Given this list of marker genes DNAJC3, SMN2, GJB1, SCN9A, BIN1 (bridging integrator 1), HARS1 (NCBI Gene Id 3035), POLG, FXN, PGM3, TYMP, FBLN5 (NCBI Gene Id 11268), MYF6, MYH14, MTMR14, OPA1, NEFL, OPA3, SLC5A6, VCP, HSPB3, COASY, ALDH18A1, SLC9A1 (NCBI Gene Id 6548), POLG2, LIFR, PNPT1, ACOX1, SQSTM1, PRPS1, SCN10A, DES, RFC1, TWNK, REEP1, MRE11, SCN11A, IGHMBP2, SPTAN1, GAN, PDK3, FAM111B, HSPB1, ORAI1, RYR1, DYSF, CRYAB (crystallin alpha B), RAI1, GNB4, SPG11, SCO2, SLC25A4 (NCBI Gene Id 7872), ATXN3, GLE1, ITPR3, MAG, GNE, TCAP, ITPR1, HSPB8, RNASEH1, GBE1, SMN1, ERLIN1, PLEKHG4, PMP2, CCDC47 (NCBI Gene Id 57003), PSMC1 (proteasome 26S subunit, ATPase 1), PEX10, COG8, RTN2, SIGMAR1, KIF1A, XK, SACS, WARS1, TOR1A, ATP6AP2, MPV17, DNM2, MFN2, STIM1, KLHL9, AARS1, CADM3, MORC2, VPS13A, JAG1, KLC2, ARL6IP1, RAB7A, MCM3AP, RRM2B, HINT1, PEX11B, SBF2, PMP22, here is a description of the gene set: species: Homo sapiens Inability to elicit tendon reflexes in the lower limbs. Areflexia of lower limbs Human Gene Set: HP_AREFLEXIA_OF_LOWER_LIMBS